The following is a description of a gene set: RUNX3 binds to complexes of beta-catenin (CTNNB1) and TCF/LEF family members. Binding of RUNX3 to CTNNB1:TCF/LEF complexes prevents their loading onto cyclin D1 (CCND1) and MYC gene promoters and interferes with WNT signaling-mediated activation of CCND1 and MYC1 transcription. RUNX3 therefore inhibits WNT-induced cellular proliferation. part of: Transcriptional regulation by RUNX3 species: Homo sapiens Reactome Pathway: RUNX3 regulates WNT signaling, and this is the list of marker genes: MYC, TCF7, CCND1, CTNNB1, TCF7L2, TCF7L1, LEF1, RUNX3